Given this list of marker genes IRF5, IFIT3, IFNA2, IFNA7, PTPN11, USP18, IP6K2, PTPN6, OAS1, IFNA17, IFIT2, ISG15, IRF1, MX1, RPS27A, IFNA14, HLA-E, OAS2, UBB, RSAD2, JAK1, TYK2, HLA-B, EIF2AK2, IRF4 (interferon regulatory factor 4), IRF7, ADAR, IFNA6, IFNA5, PSMB8, OASL, UBC, IFITM1, IFNA21, IFNA4, HLA-F, IFI27, IRF8, IFNAR1, KPNB1, IFNA1, HLA-C (NCBI Gene Id 5674), ISG20, IFITM3 (interferon induced transmembrane protein 3), IRF3, MX2, IFIT5, IFIT1, STAT1, IRF9, SOCS1, ABCE1 (ATP binding cassette subfamily E member 1), IFI35, EGR1, SOCS3, UBA52, IFNA13, IFNA16, HLA-G, OAS3, GBP2, IFNA10, IFNA8, IRF6, SAMHD1, PTPN1, BST2, IFITM2, STAT2, HLA-H, IFNAR2, IFNB1, RNASEL, KPNA1, XAF1, HLA-A, IFI6, IRF2, here is a description of the gene set: studied in species Homo sapiens Human Gene Set: REACTOME_INTERFERON_ALPHA_BETA_SIGNALING Interferon alpha/beta signaling